Given this list of marker genes SPIB, LHX6, GSTO1, MCM4, CLEC5A, ADCY10, RASGRF1, EGR1, RNF144A, BAALC, TSPAN6, MEF2C, TBCB, ACSL6, PPP2R3A, GPD1L, DST, CCDC7 (NCBI Gene Id 79741), KRT34, KLF17P1, OR3A2, ANP32CP, DENND1C, DAPK1, SET, TERT, KIR2DL5A, AAR2, DAPK2, CEACAM8, PMS2P1, TARBP1, MECOM, NUTF2, C1QA, MYL2, FBL, FEZF2, MID1, SELP, APBA1, LIMK2, GPR75, KIAA0586 (KIAA0586), OPHN1, NANOG, SSTR2, PHLDB1 (NCBI Gene Id 23187), KLK15, SOBP, SPON2, CLCN2, DCC, C22orf31, GDF2, ZAP70, KRT14, RORC (RAR related orphan receptor C), SYT2, CSF2, SLC13A2, ACTR2, DHX58, PPIG, BBS10 (Bardet-Biedl syndrome 10), VTCN1, IL3, RET, SYCE1L, ENTREP1, GTF3A, TUBB1, SIX1, ZIC4, NRCAM, GSG1, OR7E24, CCDC85B, RGS4, CYP4F12, FBXL5, COL11A1, UBE2L6, ZMYM4, PAEP, KCNJ8 (potassium inwardly rectifying channel subfamily J member 8), IMPDH2, TBL1XR1, BZW2, FGF9, ZNF532, MUTYH, RXRA, TSSK2, KLF15, KCNA5, RPA4, SPATA31F2P, SSPN, CA3, PCDHGA10, CD93 (NCBI Gene Id 54591), PRR5L, PEG10, KRTAP1-3, HMGCS2, TLR8, AQP8, PSMB8, IL25, PKLR, C19orf73, AIDA, ABHD11, SH3BGR, COL6A2, PYGB, PEX5L, HIBCH, PLA2G2D, SOX17 (NCBI Gene Id 64321), TMEM230, ZBTB7C, MTHFD1, CBR4, HAUS5, BPHL, FOXL1, GNG3, HERC5, ZNF573, BTG2, ASCC1, NHP2, MTAP, FIBP, HMGB1, SARM1, RCL1, MAPKAPK3, KRT32, STEAP3, APBB1, ADGRB3, RUNX2, TCF20, AIMP2, ACADL, ZNF551, LINC00652, ZFPM2 (zinc finger protein, FOG family member 2), KIR2DS3, LCAT, RNF17, AKAP1, GTF2H3, TRIM22, GCK, SCARF1, TBXA2R, ZNF589, GRK6, PCDHB17P, HLA-K, CYP3A4, DBI, RPLP1, PGAM2, RNF115, PUS1, CDH18, BAAT, NPPB, ITGA2B (NCBI Gene Id 3674), GATA4, FLRT3, ENDOU, VIL1, ZNF148, ASPN, DCAF4, PLEKHA1, RPLP2, GTPBP8 (NCBI Gene Id 29083), F2RL3, ABCA4 (ATP binding cassette subfamily A member 4), IQGAP2, TGM4, PCF11, USE1, KRT6A, EXO5, TARP, SPRYD7, NXT1, SGK2, SLCO1C1, here is a description of the gene set: species: Homo sapiens Genes up-regulated in bone marrow-derived macrophages: control versus Listeria infected. Macrophages phagocytose bacteria. Certain pathogenic bacteria access and replicate within the cytosol of infected macrophages and induce changes in macrophage gene expression by triggering of innate immune receptors and/or the effects of bacterial virulence factors. We used microarray analysis to identify changes in macrophage gene expression following infection with Listeria monocytogenes. Human Gene Set: GSE19374_UNINF_VS_LISTERIA_INFECTED_MACROPHAGE_UP from publication Rayamajhi M, Humann J, Penheiter K, Andreasen K, Lenz LL (PMID 20123961)